The following is a description of a gene set: Chromatin organization species: Homo sapiens Human Gene Set: REACTOME_CHROMATIN_ORGANIZATION, and this is the list of marker genes: KDM4D, SMARCD1, RBBP4, KMT2C, PRMT6, H2AC25, MTA1, ARID1B, ARID2, H2BC4, KDM3B, HDAC10, PADI2, KAT8, KMT5A, KMT5B, H2AC1 (NCBI Gene Id 221613), H2AZ2 (NCBI Gene Id 94239), YEATS2 (YEATS domain containing 2), KDM5C, ATF2, H3C6, REST, CCND1, H3C3, TAF6L, H3C4, PRDM9, H2BC1, H3C8 (NCBI Gene Id 8355), SMYD2, AEBP2, GATAD2A, PRDM16, TBL1XR1, SUPT3H, ACTL6B, NCOR1, EHMT1 (NCBI Gene Id 79813), CREBBP, H4C3, KDM2A, GATAD2B, H4C16, ELP5, H4C5 (H4 clustered histone 5), WDR77, SGF29, PADI1, H2BC3, JADE3, RUVBL1, CARM1, RIOX2, ZZZ3, H3C11, KDM3A, TADA1, BRD1, H3C7, NSD1, RUVBL2, H3C1, H4C1, H4C2, SAP130, H2BC21, PHF21A, MORF4L2, H2AC16, SETD3, H2AC17, KDM5B, JADE2, HCFC1, HMG20B, SETDB1, PHF20, NCOA1, HDAC2, MSL1, TAF5L, KDM6B, VPS72, H2BC8, H2AC19, EZH2, RBBP5, SETD6, ENY2, BCL11A, ATF7IP, KDM7A, BRWD1, SMARCD3 (NCBI Gene Id 6604), BCL7B, ELP1, H2AC14, HDAC8, H2AC7, H2BC15, SETD1B, OGT, BRD8, ING5, EHMT2, KAT6B, KDM6A, EP300, DPF3, SAP30, H4C9, KAT2B, MECOM, H2BC12, DPY30, DR1, TAF9, JMJD6, MSL2, ARID1A (AT-rich interaction domain 1A), HDAC3, H2AX, KAT14, ACTB, KAT2A, H4C15, SMARCC2, JADE1, SUPT20H, H2BC10, RPS2, PADI4, H4C8, KANSL3 (NCBI Gene Id 55683), SS18L1 (SS18L1 subunit of BAF chromatin remodeling complex), H4C4, MBIP, KDM5D, H2BC6, CHD4, H2BC18, MSL3, KDM1A, ELP4, H3C15, TADA2B, SMARCC1, SUV39H2, PBRM1, SETD7, H4C12, WDR5, H2BC17, SUDS3, KAT6A, PADI6, KMT2A, H2BC7, PRMT7, SMARCA4, H2AJ, TADA3, RCOR1, H2AC18, NCOR2, H2AC6, TADA2A, CLOCK, NCOA2, NSD3, EPC1, UTY, H4C13, SAP18, TBL1X, H2AC8, SUV39H1, RBBP7, MRGBP, KDM4B, KDM4C, SMARCD2, KANSL2, DOT1L, ARID5B, KMT5C, ARID4B (AT-rich interaction domain 4B), H4C14, H2AC12, H2BC13, MORF4L1, MTA2, BRMS1, SS18, KDM1B, H3C2, KMT2D, NFKB2, ATXN7, TRRAP, BCL11B, BRD9, SETD1A, SMARCA2, BRPF1, COPRS (coordinator of PRMT5 and differentiation stimulator), H2AC20 (H2A clustered histone 20), H4C6, PRMT5, HDAC1, NSD2, RELA, KDM2B, ING4, USP22, H2AC13, H2BC26, H2BC14, BRPF3, TAF12, SUPT7L, TAF10, H2BC5, SAP30L, KAT7, PADI3, H2AB1, MBD3, SETDB2, H3C12, PRMT3, KMT2B, H3C13, BCL7C, KANSL1, ACTL6A, H3C10, BICRA, CHD3, H2AC4, EED, NFKB1, KDM5A, CDK4, ARID4A, YEATS4, SUZ12, ELP3, JAK2, DPF2, PRMT1, ASH2L, MEAF6, PHF10, SMYD3, PHF8, ING3, ELP2, ATXN7L3, H3C14, H2BC11, BRD7, SETD2, DMAP1, HAT1, H2BC9, H2AC21, KAT5, PHF2, DPF1, ELP6, EP400, SMARCB1, MTA3, KDM4A, H4C11, GPS2, H2AC11, ASH1L, BICRAL, MCRS1, PAX3, DNMT3A, BCL7A, SMARCE1, H2AC15